Given this list of marker genes TFDP2 (transcription factor Dp-2), CDK2, CCNE2, CDK4, CDK6, CDKN1A, RB1, E2F3, TFDP1, CCND2, CCND3, E2F2, CCNE1, CDKN1C, CDKN1B, CCND1, E2F1, here is a description of the gene set: species: Homo sapiens Reactome Pathway: Aberrant regulation of mitotic G1/S transition in cancer due to RB1 defects RB1 protein, also known as pRB or retinoblastoma protein, is a nuclear protein that plays a major role in the regulation of the G1/S transition during mitotic cell cycle in multicellular eukaryotes. RB1 performs this function by binding to activating E2Fs (E2F1, E2F2 and E2F3), and preventing transcriptional activation of E2F1/2/3 target genes, which include a number of genes involved in DNA synthesis. RB1 binds E2F1/2/3 through the so-called pocket region, which is formed by two parts, pocket domain A (amino acid residues 373-579) and pocket domain B (amino acid residues 640-771). Besides intact pocket domains, RB1 requires an intact nuclear localization signal (NLS) at its C-terminus (amino acid residues 860-876) to be fully functional. Functionally characterized RB1 mutations mostly affect pocket domains A and B and the NLS. RB1 mutations reported in cancer are, however, scattered over the entire RB1 coding sequence and the molecular consequences of the vast majority of these mutations have not been studied.<br><br>Many viral oncoproteins inactivate RB1 by competing with E2F1/2/3 for binding to the pocket region of RB1. RB1 protein is targeted by the large T antigen of the Simian virus 40 (SV40), the adenoviral E1A protein, and the E7 protein of oncogenic human papilloma viruses (HPVs). part of: Aberrant regulation of mitotic cell cycle due to RB1 defects